Given this list of marker genes NUBPL, SNRPB, CLN3, SLC7A7, MTTP, CBFB, ACYP2, CDC45, MRPS31P5, HSPA6, ECE2, EPC1-AS2, AGBL5-AS1, HNRNPC, AGBL5, RBL1, NUBPL-DT, NSFL1C, GIN1, ILF2, FDX1P1 (NCBI Gene Id 81690), CCDC103, PNN, RAB11A, HMGB1 (NCBI Gene Id 3146), TRMT10A, KCTD5, ANKRD36, WWP2, RAB7A, PPIP5K2, MRPL52, EFTUD2, UFD1, UQCRC2, H4C8, RPL7L1, MMADHC, DMAP1, FAM187A, EPC1-AS1, ALG3, here is a description of the gene set: from publication Yevshin I, Sharipov R, Kolmykov S, Kondrakhin Y, Kolpakov F (PMID 30445619) species: Homo sapiens Genes containing one or more binding sites for (MCRS1) in their promoter regions (TSS -1000,+100 bp) as identified by GTRD version 20.06 ChIP-seq harmonization. Human Gene Set: MCRS1_TARGET_GENES